Given this list of marker genes SLC4A2, CD28, DOCK2, CCR2, RASAL3, IL2, HLA-A, ARG2, MAPK8IP1, CD81, CBLB, IL12B, SYK (spleen associated tyrosine kinase), PTPRC, IL18, XCL1 (X-C motif chemokine ligand 1), PRKCQ, FOXP3, HLA-E, EBI3, IL23A, SH3RF1 (NCBI Gene Id 57630), LGALS9, TNFRSF14, TGFBR2, CD274, JAK2, VSIR, NDFIP1, ELF4, ZBTB7B, CD55, TYK2, TNFSF4, IRF1, ITCH, CARD11, TWSG1, IL2RA, CLEC4G, CD3E, RIPK2, LGALS9C, ZAP70, MYC, LGALS9B, IL15, here is a description of the gene set: Human Gene Set: GOBP_ALPHA_BETA_T_CELL_PROLIFERATION The expansion of an alpha-beta T cell population by cell division. studied in species Homo sapiens